The following is a description of a gene set: species: Homo sapiens mouse primary BMDCs were stimulated with tlr ligands and gene expression changes were profiled on Affymetrix arrays Genes up-regulated in comparison of control dendritic cells (DC) at 24 h versus those stimulated with Pam3Csk4 (TLR1/2 agonist) at 24 h. from publication Amit I, Garber M, Chevrier N, Leite AP, Donner Y, Eisenhaure T, Guttman M, Grenier JK, Li W, Zuk O, Schubert LA, Birditt B, Shay T, Goren A, Zhang X, Smith Z, Deering R, McDonald RC, Cabili M, Bernstein BE, Rinn JL, Meissner A, Root DE, Hacohen N, Regev A (PMID 19729616) Human Gene Set: GSE17721_CTRL_VS_PAM3CSK4_24H_BMDC_UP, and this is the list of marker genes: TMEM50B, MRPS15, RNF38, CDC25B, CRADD, DPP7, IMP3, CXCR4, PLIN3, SVIL, MYCL, ANAPC2, GSPT2, P2RY1, MRPS24, TSPAN14, IL6ST, CBX6, SLC25A3, GPR35, PDE8A, CEP350, RTN4, TMEM106A, PTS, DLG1 (NCBI Gene Id 1739), CHMP3, LZTR1, IFITM2, CAPN2, LTBP3, CLTB, RPS3, SELENOP (selenoprotein P), IL18, NCOA3, NAGK, XPR1, BACH2, EIF4E3, NUFIP1 (nuclear FMR1 interacting protein 1), RNPEP (NCBI Gene Id 6051), RPS15A, DDX59, S100A10, TGFBR1, FKBP11, SENP3, ADNP, RNH1, ARPC1A, TF (transferrin), CDADC1, TSNAX, SYNPO (synaptopodin), ASPM, DNAJC9, TMUB2, DNMBP, BNIP3L, VPS54, GTF3C1, HEPACAM2, MKNK1, ARHGAP39, CCNB2, CD34, ITM2C (integral membrane protein 2C), TNFRSF13B, RENBP, MAPK3, RPL30, MBP, LEPROT, MYL12B, P2RY12, RPS3A, CIITA, MS4A8, HMGCS1, MEF2A, ANKRD10, KIF20A, GMPR, SCEL, CENPB, TOMM22, MOCOS, TMEM14C, RAB31, B3GNT8, ADGRE5, ADD1, MKNK2, LASP1, GDI2, S100A1, GALNT2, MAZ, THRA, FBXL20, SH3BP1, DRC3, RPL12, ADCY3, LLGL2, EPSTI1, STARD4, SYPL1, ANKMY2, CD164, TRIM39, RPL28, HNRNPU, FGF9 (NCBI Gene Id 2254), PIGQ, NAXE, DDX3X, HDAC5, ARMC7, EFHD2, CEP19, C1QC, KCNK13, RXRB, TMEM51, GRK5, SAPCD1, ESRRA (estrogen related receptor alpha), PSAPL1, RPL27A (NCBI Gene Id 84736), APOC2 (NCBI Gene Id 344), LANCL1, NFATC1, RNF2, GNG11, HLX, RAB7A, SOX4, QRSL1, EEF1B2, AUH, IGBP1, YWHAH, IFIT2, STS, TNNT1, AAMDC, LIPA, CORO2A, FHIP2A, MRC1, GAB3, CD22, INPP4A, RASSF3, PTH2R, KXD1, GPX7, CNIH4, MUC1, UNC13B, RPL6, PAG1, MITF, HIP1, RPL34, F7, RRAS2, MRPL48, BEX3, ERG28, TADA1, RPL35, CREBRF, GALT, OXR1, NFATC2IP, GLI3, PALS2, PRSS16, RAMP1 (NCBI Gene Id 10267), SLC30A5, NCOA6, NDUFS2, ZNF426, SLC37A1, XIRP1, EPS15, FAU, SLC44A3 (solute carrier family 44 member 3), RPL14, GASK1B, GPANK1, RP9, SNX2 (sorting nexin 2), FKBP1B, FAR1, C6orf62 (chromosome 6 open reading frame 62), PDLIM1 (NCBI Gene Id 9124)